Given this list of marker genes Cfd, Gzmm, Cfp, C3, here is a description of the gene set: electronically inferred by orthology from the curated human pathway Reactome Pathway: Alternative complement activation studied in species Mus musculus This event has been computationally inferred from an event that has been demonstrated in another species.<p>The inference is based on the homology mapping from PANTHER. Briefly, reactions for which all involved PhysicalEntities (in input, output and catalyst) have a mapped orthologue/paralogue (for complexes at least 75% of components must have a mapping) are inferred to the other species. part of: Initial triggering of complement